The following is a description of a gene set: Any process involved in forming the mature 3' end of an RNA molecule. studied in species Mus musculus Mouse Gene Set: GOBP_RNA_3_END_PROCESSING, and this is the list of marker genes: Zfp473, Cpsf3, Rprd1b, Fbl, Ints8, Ints6, Tent4b, Ints2, Cpsf2, Ssu72, Rprd2, Exosc8, Exosc4, Exosc2, Cstf1, Pcf11, Tent4a, Ints12, Trmt10c, Pnpt1, Clp1, Cpsf6, Exosc9, Cdc73, Tut1, Zfp36l1, Dkc1, Papola, Larp7, Zc3h3, Fip1l1, Ints6l (NCBI Gene Id 75165), Ints14, Ncbp1, Tut4, Cpsf7, Rexo5, Pabpn1, Exosc3, Ccnb1, Papolb, Slbp, Parn, Dhx36, Tent2, Papolg, Exosc7, Ssb, Rexo1, Elac2, Cstf3, Ptcd1, Lsm11 (U7 snRNP-specific Sm-like protein LSM11), Wdr33, Rbfox2, Cpeb1, Eri1, Tut7, Lsm10, Ahcyl1, Supv3l1 (suppressor of var1, 3-like 1 (S. cerevisiae)), Elac1, Nudt21, Hsd17b10, Mtpap, Angel2, Ints9, Ncbp2, Exosc5, Zcchc8, Leo1, Fbll1, Cdk9, Rprd1a, Pabpc2, Larp7-ps, Ints1, Cstf2t, Rps21 (ribosomal protein S21), Ints7, Usb1, Trnt1, Lin28b, Ints5, Lin28a, Toe1, Cstf2, Mblac1, Exosc10, Paf1, Ythdc1, Exosc6, Pnldc1